Given this list of marker genes SLC38A2, SLC6A20, SLC36A1, SLC6A15, SLC7A5, ACE2, SLC3A2, CLTRN, SLC36A2, SLC1A4, SLC36A4, SLC6A7, SLC6A17, here is a description of the gene set: Human Gene Set: GOBP_PROLINE_TRANSPORT studied in species Homo sapiens The directed movement of proline, pyrrolidine-2-carboxylic acid, into, out of or within a cell, or between cells, by means of some agent such as a transporter or pore.